Given this list of marker genes Fgf2, Gipc1, here is a description of the gene set: Reactome Pathway: TGFBR3 regulates FGF2 signaling electronically inferred by orthology from the curated human pathway studied in species Mus musculus part of: Signaling by TGFBR3 This event has been computationally inferred from an event that has been demonstrated in another species.<p>The inference is based on the homology mapping from PANTHER. Briefly, reactions for which all involved PhysicalEntities (in input, output and catalyst) have a mapped orthologue/paralogue (for complexes at least 75% of components must have a mapping) are inferred to the other species.